The following is a description of a gene set: Genes up-regulated in CD4 SMARTA effector T cells during acute infection of LCMV: Ly6c int CXCR5+ versus Ly6c low CXCR5-. from publication Hale JS, Youngblood B, Latner DR, Mohammed AU, Ye L, Akondy RS, Wu T, Iyer SS, Ahmed R (PMID 23583644) studied in species Homo sapiens Human Gene Set: GSE43863_LY6C_INT_CXCR5POS_VS_LY6C_LOW_CXCR5NEG_EFFECTOR_CD4_TCELL_UP CD4 T follicular helper (Tfh) cells provide the required signals to B cells for germinal center reactions that are necessary for longlived antibody responses. However, it remains unclear whether there are CD4+ memory T cells committed to the Tfh lineage after antigen clearance. Using adoptive transfer of antigen-specific memory CD4+ subpopulations (based on CXCR5 and Ly6c expression)in the LCMV infection model, we found that there are distinct memory CD4+ T cell populations with commitment to the Tfh and Th1 lineages. Our conclusions are based on gene expression profiles, epigenetic studies and phenotypic and functional analysis. The gene expression profiles of virus-specific CD4 T cell subets at effector and memory stages is presented here., and this is the list of marker genes: TLR1, FABP1, SLC26A8, CAPN12, SMAD7, DPP4, SEMA4B, LNPEP, NRM, BDH1, STEAP1, SNAP29, MS4A1, IL18R1, CD38, CP, EBI3, SMARCE1, TACC1, EFEMP1, CPNE3, OSM, UGCG, WASHC4, PDE9A, CAMK1D, PXN, ZNF354C, PRKCD, KDM2A, TINAG, RBM6, EMILIN1, NODAL, TEAD2, WASF2, TPD52L1, PLXNC1, RASSF4, TPMT, SYPL1, C6orf62, LPIN3, RRAS2, HOXB13, UBE2B, SKIL, KIF26A, GSK3B, APOL6, DDB2, CD19, BIRC3 (baculoviral IAP repeat containing 3), DENND5A, PCMTD1, PDE3B, WDR44, FUT8, NPHP3, PRKCB, BEND6, DENND3, GPR18, CXXC5, MYB, RAP2B, RAB18, USP9Y, DENND1A, CARMIL1, PIKFYVE, ICOSLG, GSAP, UHRF2, CYTH1, MGLL, STK17B, KIAA0040, RABEP2, MYLIP, HRC, ITPKB, TSPAN2, PECAM1, CBX2, LPCAT1, ARMC12 (armadillo repeat containing 12), PRODH2, ACP6, EXOC6B, FLT3, NRCAM, MTMR1, CENPH, AKT3, RPS6KB2, TMEM63B, NCF1 (NCBI Gene Id 653844), ARL13A, LYN, NFIC, MRPL14, MBNL1, TMEM186, HOXA10, PIM2 (NCBI Gene Id 11040), SUSD6, MS4A6A, HECA, FAM107B, BCL6, LY6D, ABCA7, GNAI1, CBX5, PLA2G2D, PHIP, MRTFA, P2RY10, TCF3, PTPRE, GPR35, TAGLN2, RBMS1, TSC1, ARID1A, AMBN, JUN, XIST, IL12A, PRKAA2, WASF1, CREB1, CBLB, CFAP184, BICRAL, CERK, PTK2B, FRAT1, DDX11, ALPL, CALHM4, CD79B, PELI1, IGLC7, CSK (NCBI Gene Id 1445), TP53, ANKRD33B, BAZ2B, IFNLR1, GDNF, CYP17A1, PIAS1, TMCC3, TMED8, PPP3CA, KCNQ1, PBXIP1, ADAM8, ACR, PPP1R3B, UNC93B1, NIBAN1, PHLPP1, APBB3, P2RX2, IDH2 (isocitrate dehydrogenase (NADP(+)) 2), LLGL2, FCHSD2, NR3C1, PDE4B, MXRA7, PCDH8, FOXC1 (forkhead box C1), SPATS1, ARHGAP32, ZFP36L1, SPACA1, BABAM2, NMNAT2, B4GALT1, SELL (NCBI Gene Id 6402, selectin L), GRAMD2B, LSP1, RASSF3, CDK6, ZZEF1, CABS1, TNRC6C, ZMYND8, VEZF1, LIMA1, VASP, IL6 (NCBI Gene Id 3569), BLNK, IFT140, FCER2, RIC1 (NCBI Gene Id 57589), BCL2